Given this list of marker genes Ly96, Ube2n, Ikbkb, Rps27a, Ubb, Birc3, Ube2v1, Ticam2, Cd14, Ube2d1 (ubiquitin-conjugating enzyme E2D 1), Tlr4, here is a description of the gene set: part of: TRIF (TICAM1)-mediated TLR4 signaling  species: Mus musculus electronically inferred by orthology from the curated human pathway This event has been computationally inferred from an event that has been demonstrated in another species.<p>The inference is based on the homology mapping from PANTHER. Briefly, reactions for which all involved PhysicalEntities (in input, output and catalyst) have a mapped orthologue/paralogue (for complexes at least 75% of components must have a mapping) are inferred to the other species. Reactome Pathway: IKK complex recruitment mediated by RIP1